Given this list of marker genes MAPKAPK3, APPL1, SNX33, STX1B, DOCK2, PYCARD, APPL2, CARMIL1, KCNN4, RAB34, MAPKAPK2, here is a description of the gene set: Human Gene Set: GOBP_MACROPINOCYTOSIS An endocytosis process that results in the uptake of liquid material by cells from their external environment by the 'ruffling' of the cell membrane to form heterogeneously sized intracellular vesicles called macropinosomes, which can be up to 5 micrometers in size. studied in species Homo sapiens